Given this list of marker genes PIN1, MSH2, PPP2CB, RPTOR, RAD51D, SCO2, PRKAG2, YWHAG, MAPK11, HUS1, SESN2, AKT2, PDPK1 (NCBI Gene Id 5170), COX6A2, MTOR, CNOT10, PRMT5, AGO3, POLR2B, NELFCD, DYRK2, RRAGB, POLR2C, UBA52, RAD17, BANP, POLR2F, POLR2K, POLR2A, CNOT6L, HIPK1, PRKAB2, COX6B2, TP53AIP1, ZNF420, CDK5R1, GTF2H4, PCBP4, ELOC, AGO1, GATAD2A, TP53RK, PERP, E2F7, FANCC, CDK2, BIRC5, RFC3 (replication factor C subunit 3), POLR2H, CASP1, PRKAG1, E2F8, TAF11, LAMTOR5, GPI, RAD50, PIP4K2A, RAD9A, TPX2, CCNA2, GTF2H3, RBL1, MRE11, UBC (ubiquitin C), EP300, TBP, TFDP2, FAS, MAP2K6, CCNB1, COX7B, PML, PPP1R13B, RABGGTA, PPP2R1B, PIP4K2C, MTA2, RRAGD, NDRG1, BCL6, BRD1, TNRC6C, BID, CASP10, TAF5, PIP4K2B, PPP2R5C, COX6B1, HDAC2, COX5A, PRDX1, POLR2D, CHEK2, COX8C (cytochrome c oxidase subunit 8C), RBBP8, MAPKAP1, COX7C, GTF2H2, GPX2, SGK1, G6PD, MDM4, GTF2H5, LAMTOR1, IGFBP3, TXNRD1, ATR, ARID3A, BNIP3L, RMI2, RAD9B, GLS, PLK3, CHD3, PRKAA1, TAF15, COX4I1, COX8A, RBBP4, CNOT11 (CCR4-NOT transcription complex subunit 11), PRDX5, ATM, LAMTOR4, NLRC4, YWHAZ, ATF2, CTDP1, MNAT1, RPA1, TP53, TNFRSF10B, TMEM219, COX7A1, RFC5, RBL2, TP73, CASP6, YWHAB, PLAGL1, L3MBTL1, CCNT2, USP7, COX6A1, UBB, PPP1R13L, TIGAR, ATRIP, TNRC6A, TNFRSF10D, ZNF385A, TAF13, ELOB, TP53BP2, NDUFA4, PLK2, CCNE1, PTEN, TAF6, CCNT1, MT-CO3, HDAC1, RPS27A, E2F4, FOS, PRKAA2, CENPJ, HIGD1C, PMAIP1, CDK5, CHM, COX5B, RMI1, KAT6A, CDK12, RBBP7, AKT3, CNOT1, TAF4, DDIT4, SMYD2, JMY, MLST8, LAMTOR3, BRCA1, BAX, CNOT8, COX6C, HIPK2, TNRC6B, TAF1L, RPA3, SETD9 (NCBI Gene Id 133383, SET domain containing 9), PCNA, CDK9, RICTOR, NOC2L, ERCC2, PRELID3A, AKT1, MAPKAPK5, RHNO1, TAF7, MEAF6, POLR2I (NCBI Gene Id 5438), CYCS, CCNK, AGO2, SUPT16H, ING2, ING5, CHD4, DDB2, CCNA1, CDKN1A, NELFE, PIDD1, TCEA1, PRR5, PHF20, ELOA2, BRD7, POLR2J, TAF1, POU4F1, TNFRSF10A, PRKAG3, COX7A2L, TSC2, MT-CO1, TAF3, RRM2B (ribonucleotide reductase regulatory TP53 inducible subunit M2B), TXN, CNOT7, TSC1, FANCI, RFC2, COX7A2, STEAP3, DNA2, TP63, TAF7L, SESN3, POLR2E, PRKAB1, CSNK2B, MT-CO2, EHMT2, APAF1, RHEB, POLR2L, CRADD, RPA2, TAF12, STK11, DAXX, GATAD2B, RNF34, NELFB, CDKN2A, PMS2, CCNE2, MDC1, MDM2, AIFM2, CDK13, EHMT1 (NCBI Gene Id 79813, euchromatic histone lysine methyltransferase 1), PRDM1, BLM, BRPF3, FANCD2, TRIAP1, TP53I3, TFDP1, PPP2R1A, MAPK14, BRIP1, AURKA, SUPT5H, TAF9B, RABGGTB, MLH1, SLC38A9, RRAGC, CSNK2A2, CSNK2A1, SSRP1, TP53INP1, NPM1, CASP2, CCNH (cyclin H), RAD1, CDK7, TNKS1BP1, BRPF1 (bromodomain and PHD finger containing 1), JUN, RFC4, E2F1, TAF4B, CDC25C, NELFA, GLS2, GTF2H1, BTG2 (NCBI Gene Id 7832), TNFRSF10C, SUPT4H1, TAF10, CDK1, GTF2F1 (NCBI Gene Id 2962), TOP3A, TTC5, GADD45A, USP2, CREBBP, SESN1, ERCC3, CARM1, CNOT4, POLR2G, PRMT1, CCNG1, YWHAQ, RFFL, GTF2F2, EXO1, PRDX2, CNOT9, AURKB, BCL2L14, CNOT3, BARD1 (NCBI Gene Id 580), PRELID1, WRN, BBC3, POU4F2, YWHAH, PIP4P1, KMT5A, ELL, CDKN1B, RGCC, MBD3, TAF9, PPP2CA, TAF2, COX4I2, CNOT2, ELOA, LAMTOR2, KAT5, CNOT6, NBN, SFN, MOV10, TOPBP1, GSR, CHEK1, YWHAE, NUAK1, AGO4, RRAGA, here is a description of the gene set: species: Homo sapiens Transcriptional Regulation by TP53 Human Gene Set: REACTOME_TRANSCRIPTIONAL_REGULATION_BY_TP53